Given this list of marker genes TRAPPC12, H3-3A, SENP6, RNF4, H3-3B, RB1, here is a description of the gene set: Any process that modulates the rate, frequency, or extent of centromere complex assembly, the aggregation, arrangement and bonding together of proteins and centromeric DNA molecules to form a centromeric protein-DNA complex. Human Gene Set: GOBP_REGULATION_OF_CENTROMERE_COMPLEX_ASSEMBLY species: Homo sapiens